The following is a description of a gene set: from publication Chen Y, Wang X (PMID 31504780) species: Homo sapiens Human Gene Set: MIR921 Genes predicted to be targets of miRBase v22 microRNA hsa-miR-921 in miRDB v6.0 with MirTarget v4 prediction scores > 80 (high confidence targets)., and this is the list of marker genes: TTYH3, ACKR3, MYH11, TPP1, SGK2, CTBP2, NIPA2, SMPX, APPBP2 (NCBI Gene Id 10513), MAGI3, TRPM6, SLCO2A1, CADM1, ADAM9, TBC1D25, PON1, GCNT3, CSRP1, TMEM260, LSAMP, TLR5, ADD3, YTHDF1, ZNF572, VPS36, TRIM67, FOXO1, NUDT15, LRRC3B, SPATA18, AMMECR1L, ZBTB18, GID4, PPM1D, CNOT6L, FOXC1, ITGA8, PRKCQ, SPRTN, KMT2C, DNAJB9, DAAM1, HSPH1, PFAS, FRAS1, CDH2, KDM7A, KCTD5, ZFYVE21, SMARCA5, NRXN3, MAP1LC3B, ZNF644 (NCBI Gene Id 90858), PTGER4 (prostaglandin E receptor 4), TRIM6, NUP107, HSF2, SELENOT, KIF2A, NAT2, NMD3